The following is a description of a gene set: Abnormal metabolism An abnormality in the function of the chemical reactions related to processes including conversion of food to enter, synthesis of proteins, lipids, nucleic acids, and carbohydrates, or the elimination of waste products. species: Homo sapiens Human Gene Set: HP_ABNORMAL_METABOLISM, and this is the list of marker genes: ALDH18A1, KHK, AMACR, CCND1, VDR (vitamin D receptor), DPAGT1, ATP6V0A2, CYP3A4 (NCBI Gene Id 1576), BCO1, TMEM199, DLAT, SLC52A1, ALDH6A1, EFL1, CAMLG, DHFR, ENPP1, PTH1R, FTCD, RFT1, COG6, MAN1B1, GALT, SLC30A10, DZIP1L, IARS1, RPL11, GUCY2C, DPM3, DNAJC21, CLCN5, PGM1, SEMA4D, GBA2, APOB (NCBI Gene Id 338), CTNS, SPTBN1, GATA1, ZNF699, HLA-DQA1, ERCC2, SLC19A1, COL7A1, PNPLA8 (patatin like phospholipase domain containing 8), TCF4, CBS, MTTP, ALG9, COG1, ACOX2, SLC2A2, SLC37A4, FARSB, CBLIF, GPR35, CYP7A1, CD320, ERCC5, MMACHC, TTPA, CASP10, GET4, COG7, SLC34A1, SLC51B, AGA, COG4, ALG13, MGAT2, STT3B, MTHFD1, ERCC4, ALG6, FGF23, FAS, COG3, DMP1, MMUT, ATP6V1A, SAR1B, SLC35A2, ALG12, ATP6AP1, TTR, MTR, ABCD4, OTUD5, COG5, COG2, CLDN16, LMBRD1, RNU4-2 (NCBI Gene Id 26836), MMAA, MPI, TCN2, RNF13, OCRL, UROS, CUBN, PMM2, CCDC115, DPM1, ALG11, CYP27B1, AMN, RPS10, ATP6AP2, MST1, SAMD9, MMADHC, HLA-DQB1 (NCBI Gene Id 7924), ALDOB, AKR1D1, ALG1, B4GALT1, MAGT1, GALNT2, CYP7B1, LRP5, ATP6V1E1 (ATPase H+ transporting V1 subunit E1), ABCD1, SUCLG1, SIM1, DOLK (dolichol kinase), TAT, ALDH4A1, PRDX1, GALNT3 (polypeptide N-acetylgalactosaminyltransferase 3), STT3A, ALG3, HCFC1, KL, FOCAD, MPDU1, SBDS, SRD5A3, GALM, CYP2R1, ALG8, SLC39A8, ELN, MMAB, SLC46A1, PKHD1, CAD, DDOST, TJP2, GRM7, GORAB, PGM2L1, ACSF3, EDEM3, FASLG, SSR4 (signal sequence receptor subunit 4), DPM2, COG8, SUCLA2, MMP1, MTRR, ALG2, SLC34A3, SLC10A1, FBLN5, ERCC3